The following is a description of a gene set: studied in species Homo sapiens Human Gene Set: chr10p15, and this is the list of marker genes: PFKP-DT, MIR3155A, IL15RA, RPL12P28, ENSG00000235281, PFKFB3, TUBB8, PFKP, ANKRD16 (NCBI Gene Id 54522), LINC00200, GDI2, KLF6, ENSG00000297481, MIR6072, PRKCQ, ENSG00000288915, RNU6-576P, AKR1C2, LINC00701, ENSG00000295332, LINC02668, RBM17, IDI2-AS1, LARP4B-DT, LINC00705, ADARB2-AS1 (ADARB2 antisense RNA 1), PFKFB3-AS1, DDX20P1, MIR6078, AKR1C5P, CALML5, IL2RA, ENSG00000287566 (NCBI Gene Id 105376380), NET1, ENSG00000309490, ENSG00000299703, RNA5SP297 (NCBI Gene Id 106479003), RNA5SP298, LINC00703, ENSG00000225140, FBH1, RNU6-889P, LINC02656, NRBF2P5, RPL26P28, RN7SL754P (NCBI Gene Id 106479497), RN7SKP78, MIR3155B (microRNA 3155b), PITRM1-AS1, AKR1C1 (aldo-keto reductase family 1 member C1), ENSG00000239142, LINC02662, LINC00700, CALML3-AS1, IDI2, LARP4B, RN7SL445P, ADARB2, AKR1C8, AKR1E2 (aldo-keto reductase family 1 member E2), LINC02669, DIP2C-AS1, AKR1C4, RPL32P23, MIR5699, IDI1, LINC02639, AKR1C7P, LINC00702, LINC02561, ARL4AP3, AKR1C3, ENSG00000229664, PITRM1, ZMYND11, TUBAL3, DIP2C, LASTR, LINC02645, GTPBP4, UCN3, WDR37, CALML3, ASB13, ENSG00000227101, RNU6-163P (NCBI Gene Id 106479638), MANCR, LINC02660, ENSG00000287235, ENSG00000251922, IL9RP2, SDCBPP1, TASOR2, LINC02649, LINC02564, PRKCQ-AS1 (PRKCQ antisense RNA 1), AKR1C6P